Given this list of marker genes NSD2 (NCBI Gene Id 7468), ALX1, DPM1, TASP1, NF1, LMBRD2, CTBP1, INTS11, FGFRL1, RSPO2, CDH11, CPLX1, NBAS, DLK1, INTS8, MEG3 (maternally expressed 3), FBN1, SPOP, ASXL2, H4C5, RTL1, PIGA, PUS7, SPTBN1, TMEM53, BICRA, ZSWIM6, TP53RK, LETM1, here is a description of the gene set: Abnormality of the glabella An abnormality of the glabella. species: Homo sapiens Human Gene Set: HP_ABNORMALITY_OF_THE_GLABELLA